Given this list of marker genes FOXI3, CDT1, GMNN (NCBI Gene Id 51053), ORC6, TWIST2, TCTN3, FANCB, CDC6, ORC1, CDC45, ORC4, here is a description of the gene set: Human Gene Set: HP_MICROTIA_THIRD_DEGREE Microtia, third degree studied in species Homo sapiens Presence of some auricular structures, but none of these structures conform to recognized ear components.